The following is a description of a gene set: Human Gene Set: HP_EOSINOPHILIC_INFILTRATION_OF_THE_ESOPHAGUS Infiltration of numerous eosinophils (usually greater than 15 per high power field) into the squamous epithelium of the esophagus, and layering of eosinophils on the surface layer of the esophagus. Eosinophilic infiltration of the esophagus studied in species Homo sapiens, and this is the list of marker genes: TGFB1, TGFB3, STAT6 (signal transducer and activator of transcription 6), STAT3, TGFB2, DSG1 (NCBI Gene Id 1828), SMAD3, TGFBR1, DOCK8, TGFBR2